Given this list of marker genes PHF2, CMKLR1, CST1, KLF8, PCDHB15, RPS16P5, BOC, MSL1, CNTLN, WDR97, UNKL, PSD, OR1C1, HCST, SRRT, COPG1, TRBV7-3, COPA, LINC02877, ATAD2B, STX5, LCOR, PNMA2, ADAMTSL2, AASS, PGAP1, CLDN8, B3GNT3 (NCBI Gene Id 10331), GSK3B, PABIR1, GLIS3, ZNF530, TEX26-AS1, GNL3LP1, SPACA6, ABCB11, COL28A1, CAPN14 (NCBI Gene Id 440854), KCNH8, CR2, DDX54, FFAR2, DCAF15, CTRL, CCDC77, C6orf132, TOMM40, TRIM64EP, ANKS3, HYAL6P, TADA3, EPN1, NIPSNAP1, SUPT6H, CDIN1, TTC9B, LUC7L2, CLPTM1, CWH43, MFSD3, PIM1, CASC22, HSD17B2, CDH7, CHKB, IQGAP1, FBXO15, PPIP5K1, RPP25, LY6G6E, GPR88, MLXIPL, NOTCH1, PKHD1L1, CDK9, HS6ST3, GRID1-AS1, MGAT5B, PEX5, RTKN2, ELMO3, MNX1, MAP3K15, PTRH1, SAMD4B (sterile alpha motif domain containing 4B), CARMN, KCNH5, RTL10, KCNA6, MTTP, ICAM4, RAD54L2, AGXT, IFNK, MRO, F2RL2, NKX6-2, RPE65, PKD1L1, HIF1AN, ARMC6, RPL23AP53, SCUBE1, SMIM17, EBLN2, ACOT7, SMIM32, GANAB, SNRNP40, NCS1, USP26, C1QB, HOXB8, CNN3, POMC, LONP2, PRSS22, DHX35, MS4A5, INSYN2A, AKAP10, CEMIP2, DRC3, SPATA25, EXOSC4, MIA, MAGEA8, CADM4, RELN, CA6, B3GLCT, UBASH3A, CNOT9, LEKR1, NF1, EIF5, TRIP6, CLASP1, NFIC, B4GALT2, C20orf202, GEN1, IL34, NPEPPSP1, GREP1, SLC6A20, SLC50A1, EML2, FKBP9, MT1E, ZNRF2P1, MX2, LINC00311, ICAM3, VRK3 (VRK serine/threonine kinase 3), TMCC3, PRKAG2-AS2, SIRT5, PPP1R10, CNTROB, VMO1, C1orf220, NRCAM, BUB1B, HOXB7, GRM8, SPOCK3, IL1A, UPB1, NMNAT1, NFX1, RBAKDN, PCBD1, STRN, CYP2F1, C16orf78, LINC00320, MAP1LC3C, RNF212, FGF17, UPF1, KANSL3, SMARCD1, VWA3B, DDX4, GARIN5B, MGAT4C, NMRK2, ANKRD17, here is a description of the gene set: We demonstrated recently that both constitutive and FAS-triggered apoptosis of human neutrophils are profoundly impaired by Francisella tularensis, but how this is achieved is largely unknown. To test the hypothesis that changes in neutrophil gene expression contribute to this phenotype, we used human oligonucleotide microarrays to identify differentially regulated genes in cells infected with F. tularensis strain LVS compared with uninfected controls. In order to examine the effect of F. tularensis on the neutrophil transcriptome, we performed microarray expression analysis on human neutrophils treated with F. tularensis subsp. holarctica live vaccine strain (LVS). Genes up-regulated in comparison of control polymorphonuclear leukocytes (PMN) at 0 h versus PMN treated with F. tularensis vaccine at 0 h. species: Homo sapiens Human Gene Set: GSE37416_CTRL_VS_0H_F_TULARENSIS_LVS_NEUTROPHIL_UP from publication Schwartz JT, Bandyopadhyay S, Kobayashi SD, McCracken J, Whitney AR, Deleo FR, Allen LA (PMID 22986450)